The following is a description of a gene set: studied in species Homo sapiens Human Gene Set: HALLMARK_KRAS_SIGNALING_DN from publication Liberzon A, Birger C, Thorvaldsdóttir H, Ghandi M, Mesirov JP, Tamayo P (PMID 26771021) Genes down-regulated by KRAS activation., and this is the list of marker genes: ZC2HC1C, AMBN, BARD1, VPS50, RGS11, TGFB2, TGM1, PRKN, GP1BA, RSAD2, IFNG, FGFR3, KCNE2, SOX10, NUDT11, STAG3, CCR8, CDH16, SERPINB2, PDK2, GAMT, FSHB, AKR1B10, SLC29A3, SLC6A3, HTR1D, SLC30A3, SCGB1A1, GP2, SNN, ENTPD7, NR4A2, TLX1, LGALS7, COL2A1, SELENOP, IRS4, TFCP2L1, SYNPO, ABCG4, RYR1 (ryanodine receptor 1), CLPS, ATP4A, BRDT (bromodomain testis associated), SLC16A7, LYPD3, GPR3, DLK2, TCF7L1, PAX4, NTF3, CALML5, KLK8, NR6A1, BTG2, SERPINA10, CKM, P2RX6, ADRA2C, VPREB1, LFNG, CLSTN3, CPEB3, PROP1, EDN1, COPZ2, KCNQ2, MYOT, TENM2, NOS1, TEX15 (testis expressed 15, meiosis and synapsis associated), ABCB11, SSTR4, GRID2, TSHB (NCBI Gene Id 7252), PDCD1, INSL5, PTPRJ, FGGY, ACTC1, CPA2, CCDC106, YPEL1, SLC5A5, CD80, HSD11B2, UPK3B, EDN2, IGFBP2, ITGB1BP2, MYO15A, MEFV, CNTFR (ciliary neurotrophic factor receptor), CHST2, TFF2, KRT15 (keratin 15), HTR1B (NCBI Gene Id 3351), THNSL2 (threonine synthase like 2), C5, GPRC5C, SLC6A14, SKIL, SPTBN2, PAX3, CACNA1F, CYP39A1, PNMT, KMT2D, SPHK2, IDUA, MX1, SLC38A3, RIBC2, CELSR2, CCNA1, SIDT1, OXT, MFSD6, KCND1 (potassium voltage-gated channel subfamily D member 1), PCDHB1, SMPX, GDNF, CD40LG, KLK7, SGK1, NPY4R, TCL1A, ARPP21, KRT13, ZBTB16, MAST3, TG, SPRR3, UGT2B17, DCC, CAMK1D, TNNI3, TFAP2B, SCN10A, CYP11B2, KCNN1, YBX2, CACNG1, SNCB, CLDN8, CDKAL1, TAS2R4, PDE6B, CD207, CAPN9, MAGIX, EPHA5, GTF3C5, BMPR1B, IL5, ALOX12B, SLC12A3, THRB (thyroid hormone receptor beta), ITIH3, MACROH2A2, IFI44L, IL12B, RYR2, KLHDC8A (kelch domain containing 8A), HNF1A, SHOX2, FGF22, NGB, ARHGDIG, MYH7, PKP1, EFHD1, MSH5, P2RY4 (pyrimidinergic receptor P2Y4), TENT5C, KCNMB1, KRT1, COQ8A, DTNB, WNT16, GPR19, ZNF112, CLDN16, EGF, EDAR, FGF16, MTHFR, CPB1, PTGFR, KRT4, PRODH, SLC25A23, ASB7, CHRNG, CALCB (NCBI Gene Id 797), PLAG1, NRIP2, ATP6V1B1, KRT5, NPHS1